Given this list of marker genes PTGER1, CAV2, GNAS, VPS35, SNX5, DLG4, ARRB2, here is a description of the gene set: Binding to a D1 dopamine receptor. species: Homo sapiens Human Gene Set: GOMF_D1_DOPAMINE_RECEPTOR_BINDING